Given this list of marker genes TEX261, BDP1, EXO5, GK5, TCP1, PSMD1, POM121L10P, LINC00941, SART1, ACBD5, EMC10, MAPKAPK3, NIPSNAP2, C2orf49, CLDND1, VIM, KRTAP2-4, GLCE, ST7-AS2, MSR1 (macrophage scavenger receptor 1), API5, UBR4, NR1H2, KMO, LILRB3, HPS5, RFK, KCNE1, KCNJ14, DYNLT3, CCDC93, TBX19, BUD13, ZFR, C2, NUCB1 (nucleobindin 1), C3orf70, VPS35, EREG (epiregulin), HAUS7, ACSS2 (NCBI Gene Id 55902), KIF18A, ZNF75A, RMST, UNC50, CEP126, CD300LF, KIAA0930, GADL1, LILRA6, LILRA3, HSBP1, DLD, ZNF786, ABHD11 (abhydrolase domain containing 11), SPATA6, ARAP2, SH3GL3, LINC02880, EBF2, ANXA2P3, ARL6IP1, GPR85, POGZ, PLK1, ZNF778, UBE2Z, EFCAB14, NFE2L1, KCNJ13, ARHGAP11A, NEK10, POLK, MSANTD1, SGO2, CASD1, ZNF705G, BAZ2A, GTF2E2, GFOD1, MED14, UBR1, CENPI, PLPPR1, CTNNB1, LONRF2, S100A8, GTF2F2, FOXR1, TPTEP1, ARHGAP29, VPS4A, SLC6A16, ERICH1, FBP1, FLII, MAP7D3, TPT1-AS1, MYOF, TSSC4, RASSF6 (Ras association domain family member 6), NUMA1, ZBTB20, VIPAS39, DTHD1, PDPK1, SLC9A9, FABP2, C1orf50, EMP3, AASS, CASC2, CDC40, MR1, ATXN2, TBC1D8B, THRB, TEDDM1, ELOB, ORC1, SETD3 (NCBI Gene Id 84193), SFT2D2, NEK2, VAV1 (NCBI Gene Id 7409), IGHV1-69, DNASE1L2, AREG, LINC01242, ARAP1, DHRS7B, CAST, STIL, POLG, CDC42, MAP3K7, KIF16B, PLA2G4A, TTI2, LRRC25, WASHC4, AUNIP, PLPBP (pyridoxal phosphate binding protein), ALOX15B, ARSA (arylsulfatase A), TPPP3, FIRRM, ARL16 (NCBI Gene Id 339231), MYO1G, PSEN1, SIGLEC9, CALM2, DNAJB7, PPP2R1A, CCL20, SLC4A1AP, HDHD2, TMEM106B, EEIG2, ACVR1B (NCBI Gene Id 93351), RARA, ANKRD30B, SPAG11A, KATNA1, ZUP1, NPAT, RNF126P1, CPB1, NNMT, SESTD1, MAP2K6, KIF23, NIPSNAP3A, RUNX1 (RUNX family transcription factor 1), SCRN1, EZR, DHFRP3, SYNGR2, RHOBTB2, CDH19, ENSG00000224715, MECOM, ZBTB3, MICU2, ZNF626, HIPK2, FTSJ3, TBXAS1, TAF2, EFCAB3, GUCY2C, UBL5, CHM, CNTNAP2, NHLRC2, DBIL5P2, here is a description of the gene set: Human Gene Set: GSE45365_WT_VS_IFNAR_KO_BCELL_UP studied in species Homo sapiens Genes up-regulated in B lymphocytes: control versus primary acute viral infection. Murine Cytomegalovirus (MCMV) infection leads to early activation of various immune cells, including B and T lymphocytes, before the actual initiation of antigen-specific adaptive immunity. This activation is partly driven by innate cytokines, including type I interferon (IFN), which are induced early after infection. The objective of this study was to address the role of type I IFN in shaping early/innate B and T cell responses to a primary acute viral infection. In order to decipher the specific impact of IFN-I on cell subsets, we performed a genome-wide expression analysis on WT splenic B and CD8 T lymphocytes isolated from C57BL/6 mixed bone marrow chimera mice. This study complements series GSE39555, which focused on early responses of NK cells and of the two subsets of conventional dendritic cells.